Given this list of marker genes RALGPS2, LPAR2, KLF3, SLC9A9, ANXA1, SPON2, VAV3, SAMD4B, MAP4K4, YPEL3, ITPKB, NLRP1, ZNF101, PARP8, IRF2BP2, KCNA3, GPRASP1, OSER1, CLEC4E, RASA3, PSTK, CDC14A, KRT73, HCST, VNN2, YPEL5, GADD45A, TENM1, LYPD3, PDE4B (NCBI Gene Id 5142), VWA5A, KLRB1, GAL3ST4, ZFAND2A, CDK5R1, ZNF8, PGAP3, FAM228B, TRPS1, SYNM, ASH1L-AS1, MXD1, ZNF880, EMB, LDB2, FAM8A1, SCARNA17, LINC00173, TPM2, FBXO32, LZTFL1, IL7R, DNAH5, IRS2, TNFSF8, WASF2, STAG3L4, YPEL2 (NCBI Gene Id 388403), TP53INP1, APRG1, RRN3P1, C16orf74, JUNB, ZNF805, LEPROTL1, HLA-DRB6, CFP, NR4A2, PLXDC1, KAT6A, SGK1, ERO1B, PLCXD2, FHIT, CCDC141, PCIF1, ERP27, TSIX, SKIL, LINS1, MICAL1, HYKK, SUSD4, PCDH9, ITPRIP, TXK, ZNF256, GABBR1, IFT20, KLF4, ARRDC2, SOX4, BIN2 (bridging integrator 2), SLC26A11, ST6GALNAC1, MORC2-AS1, PPP1R12B, RAP1GAP2, MYLIP, EPHA4, ARRDC3, PITPNC1, ZNF10, BTG2, ZNF669, C6orf226, FES, CTSK, ZBTB10, CRTC3, TNFAIP3, GPR65, ITCH, HABP4, C11orf21, MDS2, GSE1, ATP2B1-AS1, LINC02035, PIK3R5, MLNR, SOX14, COQ10B (NCBI Gene Id 80219), MAPKAPK5-AS1, ZNF211, TYROBP, RGS2, UPP1, JMY, TIGD1, GPR153, VPS9D1, IL11RA, PIK3IP1, MIR22HG, CEP68, MEF2D, BAG3, KLHL3, LMNTD2 (NCBI Gene Id 256329), CITED2, CLK1, ZFAND3, ZNF844, ENC1, SLC2A11 (solute carrier family 2 member 11), DPEP2, RASGRP2, KLF2, ADPRM, ZNF34, ENSG00000274253 (NCBI Gene Id 283683), PELI2, NFYC-AS1, AK5, MYH11, LAMB2P1, ATG14, ITGA6, RORA, WHAMM, ZFYVE28, APOBEC3A (apolipoprotein B mRNA editing enzyme catalytic subunit 3A), ITGAM, RNF10, SIK1, TXNIP, TOB1, FOSL2, FOS (Fos proto-oncogene, AP-1 transcription factor subunit), OSBPL10 (NCBI Gene Id 54907), SOX6, TSC22D3, DUSP1, CRYBG1, TNFRSF10D, PCSK5 (proprotein convertase subtilisin/kexin type 5), TCF7L2, REM2, MSX2, CLEC11A, MAFF, CNBD2 (cyclic nucleotide binding domain containing 2), TGIF1, TBC1D10A, ARL14 (ADP ribosylation factor like GTPase 14), VTI1A, ZNF394, TMEM156, ZDHHC11, AMT, here is a description of the gene set: Human Gene Set: GSE17974_0H_VS_24H_IN_VITRO_ACT_CD4_TCELL_UP studied in species Homo sapiens from publication Elo LL, Järvenpää H, Tuomela S, Raghav S, Ahlfors H, Laurila K, Gupta B, Lund RJ, Tahvanainen J, Hawkins RD, Oresic M, Lähdesmäki H, Rasool O, Rao KV, Aittokallio T, Lahesmaa R (PMID 20620947) The aim of this dataset was to study in detail the transcription kinetics initiated by cytokine IL-4 in early differentiation of Th2 cells. Genes up-regulated in comparison of untreated CD4 T cells at 0 h versus the untreated cells at 24 h.